Given this list of marker genes Atp4a, Cps1, Kcna4 (potassium voltage-gated channel, shaker-related subfamily, member 4), Kcnj11, Pdxk, Scn8a, Impa1, Pklr, Scn9a, Tdg-ps, Scn2a, Scn1a, Capn3, Slc6a4, Pkm, Adprh, Kcnj1, Scn3a, Drg1, Atp1a2, Hdac4, Acat1, Tdg, Slc34a2, Amelx, Atp1a1, here is a description of the gene set: Binding to an alkali metal ion; alkali metals are those elements in group Ia of the periodic table, with the exception of hydrogen. species: Mus musculus Mouse Gene Set: GOMF_ALKALI_METAL_ION_BINDING